The following is a description of a gene set: species: Homo sapiens Human Gene Set: NABA_ECM_AFFILIATED from publication Naba A, Clauser KR, Hoersch S, Liu H, Carr SA, Hynes RO (PMID 22159717) Genes encoding proteins affiliated structurally or functionally to extracellular matrix proteins One hallmark of ECM proteins is their domain-based structure. Exploiting this characteristic, we established a list of diagnostic InterPro domains commonly found in ECM proteins. We know that some of the domains used to select positively for ECM proteins are also found in transmembrane receptors and proteins involved in cell adhesion (growth factor receptors, integrins, etc) that do not belong to the ECM. These families of proteins also display a subset of specific domains and transmembrane domains incompatible with definition as “extracellular matrix” proteins. Therefore, a second step comprised a negative selection using another set of domains and a transmembrane domain prediction. Manual curation of the matrisome lists also allowed us to add a very few known ECM proteins that do not contain any known domains. Protein-centric predictions were then converted to gene-centric lists. Finally, knowledge-based annotation of these gene lists allowed us to define subcategories within the core matrisome; namely, ECM glycoproteins, collagens, and proteoglycans. We also defined separate lists of domains commonly found in 1) ECM-affiliated proteins (proteins that share either some architectural similarities with ECM proteins or that are known to be associated with ECM proteins; 2) ECM regulators: ECM-remodeling enzymes, crosslinkers, proteases, regulators etc.; 3) secreted factors, many of which are known to bind to ECM and others that may. As for the core matrisome list, we also defined lists of domains that excluded mis-assigned proteins from these categories. Using similar bioinformatic pipelines as for the core matrisome, we defined three categories of “matrisome-associated” proteins: ECM-affiliated proteins, ECM regulators, and secreted factors., and this is the list of marker genes: GREM1, CLEC1A, ANXA13, SEMA4G, CLEC2D, SEMA6A, PLXDC2, C1QL1, FREM3, LMAN1, ANXA3, MUCL1, PARM1, GPC2, CLEC5A, SEMA4D, C1QL2, MBL2, CLEC7A, LGALSL, OVGP1, ANXA8, C1QC, CLEC2L, COLEC12, LGALS8, SEMA7A, PLXNB2, CLEC4G, HPX, SEMA6C, ANXA8L1, LGALS1, CLEC2B, SDC3, MUC15, MUC12, CLEC10A, SEMA6D, C1QTNF2, MUC21, CLEC4D, CLEC4M (NCBI Gene Id 10332), ANXA5 (NCBI Gene Id 308), SEMA4B, MUC22, MUC1, MUC16, PLXNA2, C1QTNF4, SEMA4F, LGALS9, LGALS3, SEMA3C, SFTPB, ELFN2, SEMA5A, C1QTNF6, REG1A, MUC2, GPC3, FREM1, CLEC18A, LGALS2, SEMA3B (semaphorin 3B), LGALS13, ANXA9, CLEC12B, SEMA4C, SEMA3E (semaphorin 3E), COLEC10, PLXNC1, ANXA10, SFTPA1, MUC7, FCN1, SEMA5B, REG1B, SFTA2, LMAN1L, CLEC12A, CLEC4C, GPC1, GPC5, MUC3A, FCN2, MUC5B, CLEC19A, CLEC11A, SEMA3D, MUC5AC, MUC17, PLXDC1, CLEC18C, REG3A, C1QB, SEMA3A, REG4 (regenerating family member 4), SDC2 (NCBI Gene Id 6383), SFTA3 (surfactant associated 3), ELFN1, ANXA4, CLEC3A, LGALS9C, CLEC4E, MUC13, SDC1, C1QTNF1, PLXNA1, FREM2, LGALS4, C1QL3, SFTPD, PLXNA4 (NCBI Gene Id 91584), CD209, CLEC2A, GRIFIN, C1QTNF9, LGALS14, C1QTNF8, C1QTNF5, PLXNB3, REG3G, ITLN2, CLEC17A, ANXA7, SFTPC, CLEC18B, PLXNB1, MUC19, CLEC4A, CLEC9A, GPC6, CLEC3B, SEMA3F, CLEC6A, LGALS9B, MUC20, FCN3, CLEC1B, C1QTNF7, COLEC11, SFTPA2, EMCN, CLEC14A, PLXNA3, CLC, C1QL4, SEMA3G, CSPG4 (NCBI Gene Id 1464), CLEC4F, C1QA, ANXA2 (annexin A2), ANXA1, MUC6 (mucin 6, oligomeric mucus/gel-forming), SEMA6B, LGALS7, CSPG5, SDC4, LGALS16 (NCBI Gene Id 651102), PLXND1, ITLN1, OPRPN, SEMA4A, LGALS12, C1QTNF3, ANXA11, MUC4, ANXA6, GPC4